Given this list of marker genes MTA2, LAMTOR4, CCDC125, SOCS6, TIFAB, RAD51AP1, TNFRSF13B, COMMD8 (NCBI Gene Id 54951), UBXN1, THBD, SIGIRR, TBRG1, YPEL3, FAM107B, RASSF3 (Ras association domain family member 3), XBP1, IFT80, DDX50, TTC9C, KLHL24, PMM1, CEP97, TTC4, KIFC1, TOB1, TNFAIP8L2, WDR45, SEPTIN10, PLK4, RPL7, MZT2B, CSNK2A2, GPX1, SCP2, RPS6KA5, ERCC6L, NEURL1B, ZNF260, BPNT2, RPS18, AHCY, SELENOM, YPEL2, BORA, RTCB, FBXL8, SLF2, TMEM183A, SEPTIN6, CFAP20, SERINC5, LMNB2, RPL34 (NCBI Gene Id 6164), TERF1, PDCD4, FRAT2, PAFAH2, GNB1, ERGIC3, TMPO, CEP20, PARPBP, YIPF4, LSP1, IMP3, MSL3, PON3, EXO5 (exonuclease 5), POLDIP2, UBE2B, HASPIN, MDC1, UEVLD, NANS, CD109 (NCBI Gene Id 135228), C4orf46, KCTD9 (potassium channel tetramerization domain containing 9), ADSS2, RSF1, PTRH2, HAUS5, ULK2, MAGED2, STK26, ENTPD5, BBS9, INIP, POT1, PHF19, TOMM22, HACL1, GINS1, DOK3, FAM151B, NAT9, ZBTB8A, TJP3, TAF9, RPLP1, RACK1, SMIM13, CWC25, H2AX, WEE1, DDX11, TXNIP, PABIR2, VPS26C, SLC44A2, ZNF652, SMPD1, C19orf38, TMEM263, CEP57, RNF180, TEF, TSC22D3, LY6G6D, MCUB, CAPG, RFWD3, MCM8, PAICS, ZMYM2, MICOS13, CCNI, KIF22, NTAQ1, ATP2A3, KIF18B, FMO5, ING2, CIR1, TUBB4B, NUBP1, UFSP2, ERLIN1, DAZAP1, SHB, BRD8, SIRT3, PIAS2, IQCC, EIF2S3, HSPB6, CSTPP1, CKS2, BTG2, NDUFB11, PI4K2B (NCBI Gene Id 55300), PIP4K2A, CEP44, RPL41, FUCA2, CENPO, LRWD1, MANBA, NOP53, UBE2J2, UROD, HINFP, REEP4, TRMT2B, SLC66A3, HNRNPA2B1, ANKRD44, CHCHD3, COPS5, SNTA1, ZNF622, TMT1A, AGO4, AP5S1, SMC4, ACP6, H2AZ1, BTF3, RPS5, WARS2 (NCBI Gene Id 10352), UBALD2, PMS2, PFDN5, VPS13A, TSGA10 (testis specific 10), CEP89, SLC39A8, KDM2B, CDC25C, RPS8, PCMTD2, NUP50, SPC24 (SPC24 component of NDC80 kinetochore complex), DAP3, ANKRD37, ADPRM, PRR13, NARF (nuclear prelamin A recognition factor), PLP2, PCYOX1, GMNN, here is a description of the gene set: from publication Mold JE, Venkatasubrahmanyam S, Burt TD, Michaëlsson J, Rivera JM, Galkina SA, Weinberg K, Stoddart CA, McCune JM (PMID 21164017) Genes up-regulated in thymic implants from fetal liver versus those from adult bone marrow. Human fetal and adult hematopoietic stem cells (HSC) were obtained from fetal liver, fetal bone marrow (BM), and adult BM. These were injected into human fetal thymic implants in SCID-hu Thy/Liv mice (4-6 separate mice per HSC donor) and allowed to mature into single positive CD4+ (SP4) thymocytes over the course of 7-8 weeks. SP4 thymocytes from injected stem cells were subsequently sort-purified from thymic implants and gene expression was performed. studied in species Homo sapiens Human Gene Set: GSE25085_FETAL_LIVER_VS_ADULT_BM_SP4_THYMIC_IMPLANT_UP